The following is a description of a gene set: Human Gene Set: GOMF_PORIN_ACTIVITY species: Homo sapiens Enables the transfer of substances, sized less than 1000 Da, from one side of a membrane to the other. The transmembrane portions of porins consist exclusively of beta-strands which form a beta-barrel. They are found in the outer membranes of Gram-negative bacteria, mitochondria, plastids and possibly acid-fast Gram-positive bacteria., and this is the list of marker genes: VDAC2, VDAC3, BAK1, TOMM40, VDAC1, TOMM40L